The following is a description of a gene set: species: Homo sapiens Human Gene Set: GOBP_NUCLEAR_TRANSCRIBED_MRNA_CATABOLIC_PROCESS The chemical reactions and pathways resulting in the breakdown of nuclear-transcribed mRNAs in eukaryotic cells., and this is the list of marker genes: NOCT (NCBI Gene Id 25819), DIS3, POLR2G, DIS3L2, SKIC8, TUT7, PAN3, UPF3A, PARN, TNRC6B, UPF1 (UPF1 RNA helicase and ATPase), PYM1, ZFP36L2, LSM1, CNOT9, CNOT6, PABPN1L, PNRC2, MRTO4, EXOSC10, XRN1, CNOT2, TENT4B, UPF3B, PAN2, PNRC1, DDX5 (DEAD-box helicase 5), CNOT10, EXOSC3, GTPBP2, EXOSC2, SYNCRIP, EXOSC5, ZFP36L1, EXOSC9, EDC4, IGF2BP1, CNOT1, EIF4ENIF1, SAMD4B, TESK1, RNPS1, PELO, RC3H1, CNOT11, GSPT2, EDC3, DXO, MLH1, THRAP3, RBM8A, CAPRIN1, EIF4A3, SMG9, NCBP1, TUT4, ZFP36, DCP1B, MTPAP, DHX34, SSB, EXOSC8, YBX1, TUT1, SMG6 (NCBI Gene Id 80091), TNKS1BP1, DHX9, HNRNPU, DCP1A, XRN2, ATM, TNRC6A, SAMD4A, TNRC6C, TOB1, SKIC3, A1CF, ZCCHC7, EXOSC7, HBS1L, MAGOH (mago homolog, exon junction complex subunit), SKIC2, TENT2, EIF3E, EXOSC4, APOBEC1, PNLDC1, PATL1, UPF2, ERI1, AGO2, DCP2, SMG8, PDE12, CPEB3, TENT4A, ETF1, MAGOHB (mago homolog B, exon junction complex subunit), NT5C3B, NBDY, NBAS, CASC3, CNOT4, HNRNPAB, GSPT1, SECISBP2, EXOSC6, CTIF, AGO1, LSM7, CSDE1, NCBP2, PATL2, SMG5, BTG2, PAIP1, PABPC1, LSM4, CNOT3, HNRNPD, CNOT7, DCPS, ZC3H12A, CNOT8, SMG7, DHX36, CNOT6L, RC3H2, SMG1